The following is a description of a gene set: species: Mus musculus Mouse Gene Set: GOBP_REGULATION_OF_PIGMENTATION Any process that modulates the frequency, rate or extent of the deposition or modulates the distribution of coloring matter in an organism., and this is the list of marker genes: Bloc1s5, Zeb2, Gnat2, Spns2, Tpcn2, Adamts9, Edn3, Vps33a, Ihh, Bax, Bloc1s6, Bcl2, Adamts20, Gnat1, Bcl2l11, Kitl (NCBI Gene Id 17311)